The following is a description of a gene set: Erysipelas species: Homo sapiens Human Gene Set: HP_ERYSIPELAS Increased susceptibility to erysipelas, as manifested by a medical history of repeated episodes of erysipelas, which is a superficial infection of the skin, typically involving the lymphatic system., and this is the list of marker genes: FLT4, GJC2, ADAMTS3, KIF11, MEFV, FAM111B, FAT4, TNFRSF1A, PIEZO1, ANGPT2, CCBE1